The following is a description of a gene set: Reactome Pathway: Synthesis of PIPs at the ER membrane At the endoplasmic reticulum (ER) membrane, phosphatidylinositol (PI) and phosphatidylinositol 4-phosphate (PI4P) are interconverted. part of: PI Metabolism species: Homo sapiens, and this is the list of marker genes: SBF1, PI4K2B, PI4KA, MTMR2, SACM1L